Given this list of marker genes FASTKD1, RAP1A, ANP32B, SLC15A4, CRTAP, HCFC1, C6orf136, IPO4, NDUFB3, NLK, MGAT2 (NCBI Gene Id 4247), DPP7, MRPL48, MFSD4B, MIDN, TRMT1, ARMC6, TMEM33, SEC16A, LZTR1, RNH1, DNAJC9, TIAM1, ANLN, STRA8, CCDC115, LDLRAP1, VDAC1, EMC10, PPP1R18, FAM162A, RPS15A, NUDC, ZNF287, RPL6, SLC25A39, MRPL51, MCM7, TGFBI, MRPL36, H2AX, GRB2, SKP1, SCP2, TGFBR1, XBP1, VOPP1, CNOT6L (NCBI Gene Id 91275), EVI5, DIP2B, CPPED1, PTS, RAB7A, TECR, BABAM1, ATP5F1A, NEU1, PTP4A2, CXCR4, RASSF5, RGS19, DZIP1, TOMM20, OSBP, ZMYM4, NAXE, TIAL1, POLE3, SLC39A13, TXN2, AKR1B10, PALD1, PGRMC2, ARMC7, EIF3F, TMEM50B, FRRS1, ECHDC1, SUPT16H, C14orf119, SLC50A1, RRP1B, MRPL28, HIP1, DTNBP1, ECHDC3, REXO2, EEPD1, AIRN, SLC16A6, HOXA1, DMAC1, NANS, WDR20, SNX14 (sorting nexin 14), CTR9, DPH2, TBL2, TIMM10B, FAM193B, PGP, STRBP, MBL2, TESK2, TP53, C1QBP, GPS1, MKNK2, MPDU1, UGGT1, ATP5MG, NR1D2, LHCGR, PAG1, RNF126, SLC7A13, SCEL, PRKCD, GPT, NSF, SLC2A1, MDH2, STOML2, BDH1, ABCF1, HABP4 (NCBI Gene Id 22927), KLF16, KRT10, TMEM185A, FAM111A, SLC16A3, SLC4A8, TMEM203, ATOSB, CRADD, LXN, HEBP1, RAB31, PUM3, PAGR1, GDPD3, PPIL4, BRAT1, RPL13, MRPS24, FUOM, NGRN, LMNB2, CCAR2, NAF1, PLEKHG2, NUDT3 (nudix hydrolase 3), ADRB2, PMM2, ZMIZ2, CEP20, NSMCE3, ELOVL6, SLC26A6, MCM2, LDHA, TOPBP1, ALKBH4, CRCP, IDH3A, TECPR1, SSBP2, CYRIB, HELZ, KLHL22, SYNPO, RAD23A, NDUFA10, REV3L, MRPL2, MTAP, CCT6A, PLD1, RHOG, RAB1B, MED11, TAF10, EPRS1, HTATIP2, SLC25A38 (NCBI Gene Id 54977), LAPTM4B, LIMK1, ENPP1, HEXIM1, INPP5E, RGS10, EEF1B2, MAU2, CD93, IFI30, CAPN7, TMEM14C, ORC5, AKR7A2, HARS1, here is a description of the gene set: Genes up-regulated in comparison of dendritic cells (DC) stimulated with LPS (TLR4 agonist) at 0.5 h versus those stimulated at 4 h. from publication Amit I, Garber M, Chevrier N, Leite AP, Donner Y, Eisenhaure T, Guttman M, Grenier JK, Li W, Zuk O, Schubert LA, Birditt B, Shay T, Goren A, Zhang X, Smith Z, Deering R, McDonald RC, Cabili M, Bernstein BE, Rinn JL, Meissner A, Root DE, Hacohen N, Regev A (PMID 19729616) Human Gene Set: GSE17721_0.5H_VS_4H_LPS_BMDC_UP mouse primary BMDCs were stimulated with tlr ligands and gene expression changes were profiled on Affymetrix arrays studied in species Homo sapiens